The following is a description of a gene set: studied in species Homo sapiens The double lipid bilayer that encloses the nucleus, separating its contents from the cytoplasm. It consists of an inner and outer nuclear membrane, with an intermembrane space (20-40 nm wide, also called the perinuclear space) between them. The envelope is supported by the nuclear lamina and contains nuclear pore complexes, which regulate molecular transport. Human Gene Set: GOCC_NUCLEAR_ENVELOPE, and this is the list of marker genes: UNC50, MLX, SIGMAR1, NEMP1, NLRP10, NOS1AP, AHCTF1, RNF123, LEMD3, SEC13, MTA1, CHMP1B, SPDYA, PLA2G4C, NUP37, NPIPB3, RANBP2, MTDH, EBP, MRGPRF (NCBI Gene Id 219928), BCL2, DCTN1, PAFAH1B1 (NCBI Gene Id 5048), EI24, AEN, RAE1, MPL (MPL proto-oncogene, thrombopoietin receptor), DNASE1, NUP93, HTATIP2, XPOT, IPO5, BNIP3, RANBP17, TMEM18, FAM169A, ALOX5AP, CETN2, DST, ZFTRAF1, PRKG2, WTAP, POM121L2, XPO7, KPNA4, CHMP2B, TNMD, PARP8, PARP6, HLCS, MACO1, UBE2I, MAPK3, TRA2B, SCGB1A1, INTS5, ZNF354C, GABRB1, EPHA3, LTC4S, PCNA, SLC16A3, HMGA1, CHMP4BP1, PCM1 (pericentriolar material 1), PLAAT1, INSR, IGF2R, GRK5, NLRP6, POMZP3, SPATA46, SIRT1, ZC3HC1 (NCBI Gene Id 51530), PCID2, TMC8, RGPD2, ACKR2, SLC22A18, BNIP1, TMC6 (NCBI Gene Id 117165), MINDY3, TMEM176B, LEMD2, ATP2A3, RGPD3, IST1, BRIP1, GAPDH, LBR (lamin B receptor), DHX37, AAAS, STX1A (syntaxin 1A), EDNRB, MRPS14, TMPO, RB1CC1, GNAZ, MYORG, TNPO3, KPNA3, PTGER3, TERB2, CHMP6, SLC5A1, NOC4L, ANKRD17, SUMO1, NELL1, STX1B, MTMR6, TBC1D20 (NCBI Gene Id 170488), RNF13, FAF1, TOR4A, EPC1, OSBPL3, FAM156A, MYO6, IPO11, CYBB, SPAST, TMEM120B, ATRAID, APEH, PTGES, CD2AP, TXLNG, TPR, HAX1, NUP85, ITPR1, NRM, KIF5B, NUP62CL, CALR, SUV39H1, VAPA, PLPP6, RNF6, PLPP7, MVP, POM121C (POM121 transmembrane nucleoporin C), SEH1L, NUDT9, CUEDC2, UTP18, BANF1, LMNB2, NUP107, KPNA1, HOXA7, SMAD3, LRRK2, RBMX2, CNEP1R1, RRP12, NUP54, INTS2, NARF, PARP11, DPY19L2P2, ZBTB1 (NCBI Gene Id 22890), SUN3, KCNH1, EIF5A, NUP50 (NCBI Gene Id 26132), SPIN1, CENPV, OIT3, QSOX2, SORL1, CASC3, PLAAT3, SLC22A3, PHF8, CC2D1B, ATR, SMAD1, NAV3, CEPT1, ADRA1B, GHDC, NDC1, LRPPRC, ARL6IP6, LMNA, RGPD1, DNAJC2, PRR14, FAM156B, TRPC7, CPNE1, SYNE1, IPO9, POLR2M, SUN5, NPIPA1, MTOR, TMEM170A, INTS1, PHF11, CHMP3, NUP210L, RANGAP1, NPAP1, PHF20, STAU2, REPIN1, PRICKLE1, QRICH2 (NCBI Gene Id 84074), THAP7, SMPD4, DTX2, ROGDI (NCBI Gene Id 79641), SLC52A3, KLHDC2, NUP35, RNF220, WDFY3, RBM15, RAN, RTN4, RGPD6, ZMPSTE24, KPNA2, ANXA11, DNAJB12, ZBED1, SPAG4, SRSF1, MX2, CCND2, DUSP2, GCHFR, GATA6, MNS1, TMEM201, KASH5, ATF6, RRM1, OSBPL7, CHMP7, TRAPPC2B, MRPS23 (mitochondrial ribosomal protein S23), TOR1AIP1, SLC30A1, UBXN4, ERN1, MGST3, LYPLA1, AGFG1, HPN, TENT4A, RNF180, TYRO3, TERB1, PAK5, HABP4, NUP43, IFT122, TMEM97, TNKS2, VPS4A, CEMIP, DYNC2I2, DHCR7, SMOX, FXR1, GTPBP4, PUM2, IFFO1, LMNB1, BICD2, RTEL1, AQP1, DTL, TM7SF2, CHMP4C, ENY2, VRK2, DUX4, CCND1, POM121, GPX4, PARP16, LMNTD2, EMD, CETN3 (NCBI Gene Id 1070), SCRN1, TMEM53, LPIN1, PRNP, SREBF1, NUP133, TMEM168, PLA2G4A, PTGS2, MLIP, CD38, CDH5 (NCBI Gene Id 1003), PRKCZ, GNAQ, PSEN2, YEATS4, CLCA2, MCM3AP, SYNE4, CCAR1, SENP2, RNF43, WDR3, NUP210, CEP128, MGST2, NUP62, RANBP1, ENO1, PCYT1A, NEMP2, DISP3, NUP214, DES, ABCF1, IL15RA, NUP98, AMBP, PSEN1, CREB3L4, CENPF, NRXN1, MATR3, DCTN5, GUCA1B, ITGB4, SYNE2, TCHP, SURF4, NXT2, TOR3A, TEX2, ATP11B, ATP1B4, NUP160, NUCB2, SH3BGRL2, KPNB1, BCL2L10, TMEM38B, IPO8, CSE1L, SULT1E1, CALR3, TOR1A, CHMP4A, FAM209A, DDX19B (DEAD-box helicase 19B), ANXA4, CLGN, TREX1, GPER1, LMO7, DMPK, ERBIN, MFSD10, NUP88, IRAG2, DNAJC1, TMEM209, EGFR, ITPRIP, CPTP, TMEM43, NXT1, GUCY2F, TMEM33, POM121B, RBM15B, TMEM147, BCHE, H2BW1, SNCA, MTMR8, RAB29, NPC1, RAP1GAP2, LMNTD1, TUBB, KLK6, GTF3C3, SYNE3, BNIP2, NUP205, TNKS, TNRC18, CACYBP, CANX, NSMF, ZNF224, CBX5 (NCBI Gene Id 23468), CBX3, RTCB, PARP1, NUP58, FANCL, INPP4A, EIF6, BRAP, NR4A1, XPO4, CTDNEP1, CHMP1A, SDCBP, FAM209B (NCBI Gene Id 388799), POLA1, APP, C9orf72, TOR2A, CMTM3, ATP5MF (NCBI Gene Id 9551), FBXW11, MAD1L1, FAM111B, IFI27, CLMN, BAX, CHMP5, PGRMC2, SUN1, PML, CASK, RGPD4, CHMP4B, MYOF, ALOX5, NUTF2, GLE1, PAK1, GOLT1A, TOR1B, PIK3C2B, RGPD8, PRICKLE2, PDE4D, CLIC1, BCL2L1, TMEM38A, HACD3, GHRHR, RAB40B, SCAI, CHMP2A, NXF1, SHISA5, UGT2B28, CDK2, MAJIN, TMEM120A, OSBPL6, PLCB1, PLRG1, SUN2, GCH1, RETSAT (retinol saturase), ZNF383, TRIM27, TOR1AIP2, VPS4B, NUP155, MAD2L1BP, PTGDS, FZR1, ADRA1A, SNUPN, RIF1, BROX, TAF3, TTC12, P2RX6, GUCY2D, ITSN1, OSBPL8, XPO1, DNAJB14, SENP1, CCNI, NUP153, IPO7, AKAP6, S100A6 (NCBI Gene Id 6277), C12orf43, NUP42, AGPAT5, AKIRIN1, TMEM109, AK9, ABL1, MX1, DNAJB2, CDK4, NAPEPLD, TMCO5A, DPY19L2 (NCBI Gene Id 283417), NUP188, RGPD5, RAC2, MAD2L1, SORT1, AGPAT3, BNIP3L, BOK, SEPHS1, OTULINL, ITPR3, DHRS2, TMX4, LRRC59